Given this list of marker genes Hes3, Nkx6-3, Notch1, Gdpd5, Hes1, Ascl1, Serpine2, Fgf9, Nr2e1, Nodal, Rbpj, Sox5, Dll1, Hmgn2, Hmgn1, Pax6, Jag1, Msx1, here is a description of the gene set: species: Mus musculus Any process that modulates the consistent predetermined time point at which an integrated living unit or organism progresses from an initial condition to a later condition and the rate at which this time point is reached. Mouse Gene Set: GOBP_REGULATION_OF_DEVELOPMENT_HETEROCHRONIC